Given this list of marker genes BDNF, CALM1, SIN3A, CAMK4, TBL1XR1, NCOR1, GPS2, HDAC1, HDAC3, TBL1X, NCOR2, MECP2, PRKACA, here is a description of the gene set: Neurodevelopmental disorders are chronic disorders that affect the function of the central nervous system (CNS) and impair motor skills, cognition, communication and/or behavior. While these disorders frequently stem from mutations in genes that directly control CNS development, they can also be a consequence of environmental insults such as hypoxic/ischemic injury, trauma, exposure to toxins, infections and nutritional deficiencies, or be indirectly caused by mutations in metabolic genes. Disorders of nervous system development have been traditionally classified based on phenotypic traits (clinical presentation). Molecular genetics studies have revealed, however, that indistinguishable clinical presentations may result from pathogenic variants in different genes whose protein products function in connected biological pathways. On the other hand, distinct clinical presentations may be caused by pathogenic mutations in a single gene that functions in multiple biological pathways. In the future, phenotype-based classification of neurodevelopmental disorders may be replaced by a more informative pathway-based nomenclature. Biological pathways frequently impaired in neurodevelopmental disorders are signal transduction pathways such as the mTOR pathway in tuberous sclerosis complex (TSC) and the RAS/RAF/MAPK pathway in RASopathies, neurotransmission pathways as in some autism spectrum disorders (ASD), and pathways that regulate gene expression as in Mendelian disorders of epigenetic machinery (MDEM).<br><br>So far,we have annotated the role of loss-of-function mutations in methyl-CpG-binding protein 2 (MECP2), an epigenetic regulator of transcription, in Rett syndrome, a pervasive developmental disorder that belongs to the MDEM category. part of: Disorders of Developmental Biology Reactome Pathway: Disorders of Nervous System Development studied in species Homo sapiens